Given this list of marker genes FZD9, SYNE2 (NCBI Gene Id 26075), ANTXR1, NF2, UTRN, HLA-G, MYO10, ITGB3, TTYH1, ARF6, ITGA3, VASP, TBC1D10C, DMD (NCBI Gene Id 548327), GAP43, ITGAV, PDPN, PALM, here is a description of the gene set: Human Gene Set: GOCC_FILOPODIUM_MEMBRANE studied in species Homo sapiens The portion of the plasma membrane surrounding a filopodium.